The following is a description of a gene set: Human Gene Set: GOCC_NUCLEOSOME studied in species Homo sapiens A complex comprised of DNA wound around a multisubunit core and associated proteins, which forms the primary packing unit of DNA into higher order structures., and this is the list of marker genes: H2AP, H4C7, H4C2, H2AX, H1-9P, H4C9, H2BC5, H2AB2, H2BC15, H2BC18, H2AC11 (NCBI Gene Id 8969), SRCAP (NCBI Gene Id 10847), H3C11, PRM2, H2BN1, H3C4, H3C3, H2BC11, H2BC7 (H2B clustered histone 7), H3C1, PRM1, MORF4L2, H2AC19, H1-4, TNP2, PRM3, H3C12 (H3 clustered histone 12), ACTB, H3-4, H3-7, H2BC12, VPS72 (NCBI Gene Id 6944), H3C6, H4C15, HP1BP3, H2AC4, H2BC26, H2BC13, H2BC19P, KAT5 (NCBI Gene Id 10524), H2BC1, H3-5 (NCBI Gene Id 440093), H2AC15, DMAP1, H3Y2 (H3.Y histone 2), H4C5, H2BC14, H4C1, H2AC20, H2BC21, MPHOSPH8, H2BC4, SHPRH, H2AZ1, TNP1 (NCBI Gene Id 7141), H3C7, IRF4, TRRAP, H3C10, EPC1, BRD8, H2BC17, H2BW1 (H2B.W histone 1), ZNHIT1, H2AC21, EP400, H2AC17, H2AZ2, H2BC10, H1-1, H4C4, H3C15, H3C2, H3-3A, H4C13, ING3, H2AL3, MBTD1, H2AJ (NCBI Gene Id 83739), GLYR1, SPHK2, H2AC12, H2AC18, H2AC8, H2AB3, KAT6B, H1-0, CENPA, MEAF6, H3-3B, H2BW2, MACROH2A2, H4C14, H4C16, H2BC9 (NCBI Gene Id 8345), EPC2, MACROH2A1, H3C13, H2AC13, H4C8, H2AC7, MORF4L1, ACTR6, H1-3, H1-10, H2BC3, H1-6, H4C12, H1-2, ACTL6A, H2BK1, KAT6A, YEATS4, KDM1B, H4C3, H2BC6, H2BC12L, H2AC6, H1-8 (NCBI Gene Id 132243), RUVBL2, H3C8, H1-5, RUVBL1, MRGBP, H2AC16, H3C14, H2AC25, TGM2, SLF1, H2BC8, H2AB1, H2AC1, H4C6, H3Y1, H4C11